The following is a description of a gene set: Mouse Gene Set: GOBP_NEUTROPHIL_DIFFERENTIATION species: Mus musculus The process in which a myeloid precursor cell acquires the specialized features of a neutrophil., and this is the list of marker genes: Jagn1, Evi2b, Bap1 (NCBI Gene Id 69465), Ikzf1 (IKAROS family zinc finger 1), Csf2, Fasn, Inpp5d, Lbr, Fam3c, Fosl2, Dhrs7b, Trib1, Il17c, Lef1